Given this list of marker genes EXOC5, TIAM1 (TIAM Rac1 associated GEF 1), LTN1, BAHD1, GPR88, LRRC19, SKA3, SSBP2, QSER1, RBAK, YTHDC2, NRAS, PLEKHA5, BBS7, SLC38A1, HAUS6, ARL13B, MRTFB, CCDC141, PHTF2, LIN7C, VAX1, PRDM1, BLOC1S5, IKZF2, CHD7, RPS6KA6 (NCBI Gene Id 27330), NETO1, TNFAIP8L1, STX17, DNAAF2, RHPN2, CTNNA2, ATXN1, HOOK2 (NCBI Gene Id 29911), ADRB2, ACTR3C, TSPAN2, CEACAM8, LMLN, TNRC6B, ITGA7, TMEM106B, NEXMIF, SFR1, SCAI, SVBP, LYRM7, PIGA, RASGEF1A, ANKRD6, CTTNBP2NL, YAF2, MYO1C, SCLT1, RB1CC1, NEIL3, RAD23B, ZNF532, FAM184A, GTF3C3, HDAC9, ZNF736, SRSF7 (NCBI Gene Id 87459), C21orf91, STXBP5, GNB5, ZNF780B, TPM3, ALG10B, OGDH, C3orf80, FAM149A, RALGAPA1, NIM1K, DTX3L, MAT2B, DUSP19, DPP10, CCSER2, CCNT2, MGAT4A, CNTNAP4, RC3H1, RBM7, BRI3, CDH1 (cadherin 1), KLHL11, TUBB, LBX2, PPTC7, CSGALNACT2, SMCR8, SIKE1, GATA6 (NCBI Gene Id 2627), QKI, TMEM167B, C8orf48, ROCK1, SEC11C, SS18, ANKRD49, HLA-A, RNF44, LRRC3B, HES1, GPATCH2L, COL1A1, LCMT2, HSPB8, WNK3, AP1G1, DBT, ATP5MG, CEP97 (centrosomal protein 97), SAR1B, MOB1A, RABGEF1, ZFP14, MAGI1, CAPN2, PLRG1, SHCBP1, DENND1B, CAPZA2, NKAIN2, UBE2K, PIK3C2B, TCERG1L, SH3BGRL2, PPAT, PTPMT1, MAPK8, SMIM14, ARHGAP28, BAZ2A, SUSD5, NECAB1, ZNF711, INMT (NCBI Gene Id 9171), GXYLT1, EPB41L2, ANAPC10, SRSF10, SUV39H2, AAK1, PPP2R1B, ZNF493, LRCH2, MTPAP, GNA13, LCOR, KLF5, SIPA1L2, RIDA, KIF2A, CLEC4G, FBN2, CCDC170, SLC6A14, MYOZ1, NBEAL1, OXGR1, NOC3L, FAR2, HRH4, MTFR1, CCDC73, LRBA, NEGR1, RPF2, NEMF, CYB5D1, PHC3, CDCA2, LAMP3, NAA50, PPP1CC, MPZL3, PTBP3, MIER3, EIF2S1, ARPC2, ZNF614, FAM171B, C2orf49, KRIT1, COMMD8, RIMKLB, CAAP1, DIMT1, XRN1, FAM83B, TRAF3IP2, NCAPG2 (NCBI Gene Id 54892), DPYD, GPR37, BCL10, STEAP2, GSTCD, RRP15 (ribosomal RNA processing 15 homolog), MB21D2, FAM8A1, SRSF2, PDS5A, ABHD18, NUDT15, PTEN, SLC30A6 (solute carrier family 30 member 6), KMT5B, B3GALT1, RECQL, TMEM33, MPEG1, FCAR, CFL2, TM4SF20, MS4A3, SEMA4C, CHSY3, SPAG9, IARS1, ATAD5, MCUR1, ZFY, ZNF805, EPN2, ASTN2, SH3YL1, TFPI2, GPRASP1, CSK, PPM1A, PCMTD1, IVNS1ABP, KLHL31, SLC24A2, ZNF420, RPL15, ZNF136, PAIP2 (NCBI Gene Id 51247), HECW2, SEMA3A, here is a description of the gene set: Genes predicted to be targets of miRBase v22 microRNA hsa-miR-372-5p in miRDB v6.0 with MirTarget v4 prediction scores > 80 (high confidence targets). from publication Chen Y, Wang X (PMID 31504780) Human Gene Set: MIR372_5P studied in species Homo sapiens